The following is a description of a gene set: Enables the transfer of ferrous iron (Fe(II) or Fe2+) ions from one side of a membrane to the other. Mouse Gene Set: GOMF_FERROUS_IRON_TRANSMEMBRANE_TRANSPORTER_ACTIVITY species: Mus musculus, and this is the list of marker genes: Slc25a28, Slc11a2, Slc25a37, Slc40a1, Mmgt1, Slc39a14